The following is a description of a gene set: Atrophy/Degeneration affecting the brainstem Human Gene Set: HP_ATROPHY_DEGENERATION_AFFECTING_THE_BRAINSTEM studied in species Homo sapiens, and this is the list of marker genes: GNAO1, GFM2, TBP, SYNE1, PRDX3, CERS1, PNKP, ITPR1, ATP1A3, LMNB1, ATXN1, SPTAN1, DNAJC19, FARS2, DNM1L, ELOVL5, OPA1, PMPCB, TBCD, ZNHIT3, TRAPPC6B, CACNA1G, PCLO, DEGS1, RARS2, POLR1A, ECHS1, FA2H, DNMT1, TWNK, DNAJC3, TRRAP, COG8, GET4, LYRM7, ATP6V0A1, COG5, RNASEH1, SLC35A2